Given this list of marker genes PPP1R15A, SPINK1, ERCC1, CLTB, ADM, TNFAIP3, CCNT2 (cyclin T2), S100A9, BRD2, PRDM1, GAST, NR1D1, LAMA2, CCNA1, here is a description of the gene set: Human Gene Set: DAZARD_UV_RESPONSE_CLUSTER_G3 To gain insight into the transformation of epidermal cells into squamous carcinoma cells (SCC), we compared the response to ultraviolet B radiation (UVB) of normal human epidermal keratinocytes (NHEK) versus their transformed counterpart, SCC, using biological and molecular profiling. DNA microarray analyses (Affymetrix), approximately genes) indicated that the major group of upregulated genes in keratinocytes fall into three categories: (i). antiapoptotic and cell survival factors, including chemokines of the CXC/CC subfamilies (e.g. IL-8, GRO-1, -2, -3, SCYA20), growth factors (e.g. HB-EGF, CTGF, INSL-4), and proinflammatory mediators (e.g. COX-2, S100A9), (ii). DNA repair-related genes (e.g. GADD45, ERCC, BTG-1, Histones), and (iii). ECM proteases (MMP-1, -10). The major downregulated genes are DeltaNp63 and PUMILIO, two potential markers for the maintenance of keratinocyte stem cells. NHEK were found to be more resistant than SCC to UVB-induced apoptosis and this resistance was mainly because of the protection from cell death by secreted survival factors, since it can be transferred from NHEK to SCC cultures by the conditioned medium. Whereas the response of keratinocytes to UVB involved regulation of key checkpoint genes (p53, MDM2, p21(Cip1), DeltaNp63), as well as antiapoptotic and DNA repair-related genes - no or little regulation of these genes was observed in SCC. The effect of UVB on NHEK and SCC resulted in upregulation of 251 and genes, respectively, and downregulation of genes in NHEK and genes in SCC. To further analyse these changes, we used a novel unsupervised coupled two-way clustering method that allowed the identification of groups of genes that clearly partitioned keratinocytes from SCC, including a group of genes whose constitutive expression levels were similar before UVB. This allowed the identification of discriminating genes not otherwise revealed by simple static comparison in the absence of UVB irradiation. The implication of the changes in gene profile in keratinocytes for epithelial cancer is discussed. studied in species Homo sapiens from publication Dazard JE, Gal H, Amariglio N, Rechavi G, Domany E, Givol D (PMID 12771951) Cluster G3: genes increasingly up-regulated in NHEK cells (normal keratinocyte) after 6 h time point upon UV-B irradiation.